The following is a description of a gene set: studied in species Homo sapiens Human Gene Set: GOBP_NEUROFIBRILLARY_TANGLE_ASSEMBLY The aggregation, arrangement and bonding together of a set of components to form a neurofibrillary tangle., and this is the list of marker genes: MAPT, HSP90AA1, APOE, PPP2CB, MIR219A1, SORL1 (NCBI Gene Id 6653), DYRK1A, MARK2, CLU (clusterin)